The following is a description of a gene set: Genes containing one or more binding sites for (ZMYND11) in their promoter regions (TSS -1000,+100 bp) as identified by GTRD version 20.06 ChIP-seq harmonization. species: Homo sapiens from publication Yevshin I, Sharipov R, Kolmykov S, Kondrakhin Y, Kolpakov F (PMID 30445619) Human Gene Set: ZMYND11_TARGET_GENES, and this is the list of marker genes: MTND5P11, PPP1R35-AS1, SLC39A11, ARL6IP5, PTGES2, YAP1, SNORD68, RPL13, NDST1-AS1, MIDN, MRPL12, B3GALT4, GTPBP3, MIR6821, NBEAP1, MT-ND4, STAT3, GRAMD2A, MTND1P15, MFSD11, CDK1, PTGES2-AS1, COL1A1, MIR1538, SMG1P3, ECI1, HNRNPA0, JMJD8, TCF3, ENSG00000267053, MBD3, VANGL2, PTBP1, EEF1D, NFYB, MOB4, FAM230G, CTNNA1, MT-CYB, CTNNA1-AS1, MTCO3P12, CDT1, MVP-DT, ARHGDIA, PUS1-AS1, OAZ1, MT-TP, TADA1, SDK1, RPL8, SRSF2, NFAT5, ACTB (actin beta), KAT6A, SNORA17B